The following is a description of a gene set: Inflammation of the liver. Human Gene Set: HP_HEPATITIS species: Homo sapiens Hepatitis, and this is the list of marker genes: MMEL1, SEMA4D, ACP5 (acid phosphatase 5, tartrate resistant), RFXANK, TCF4, COG6, VIPAS39, HBB, PIK3CA, IL17RC, AKR1D1, FAS, POU2AF1, GPR35, PIK3R1, HSD3B7, CD79B, MET, SHPK, CYP7B1, IFIH1, CASP10, IL12RB1, TCF3, GNAS, TNFSF15, ARPC5, STAT1, TBX19, FOXP3, SH2D1A, CD79A, APC, BLNK, SLC25A15, AMACR, C4B, GUSB, TPP2, IL12A, MST1, C1S, AXIN1, IL18BP, CYP7A1, IGHM, CIITA, RFX5, XIAP, SPIB, IRF5, IGLL1, IL17RA, ALMS1, KRT18, CLEC7A, IGHG2, TNPO3, TP53, GLIS3, IL21R, FASLG, BTK, CD3E, SPI1, VPS33B, LRRC8A, AIRE, TTC7A, SYK (spleen associated tyrosine kinase), SLC39A7, IGKC, PIEZO1, SERPINA1, PGM1, PI4KA, CASP8, CD247, PDGFRL, CD3D, CTNNB1, TRAF3IP2, IGF2R, ITCH, CD40LG, COG8, RFXAP, ATP7A, ATP7B, FOXN1, IL17F, SKIC2